Given this list of marker genes CASP8AP2, CD8B, KLHL11, INSM1, TRIM21, ANKRD40, JAKMIP2, TNFSF13, PDLIM2, CNR1, ESPL1, ZCCHC24, SNN, DHX58 (NCBI Gene Id 79132), TTLL4, ZSCAN12, LMNB1, MRGBP, CA12, ASF1B, DDX60, IGHV3-7, BAIAP2, ZNF135, EHMT2, PALMD (NCBI Gene Id 93975), TCL6, TMEM131L, MRPL28, POLD1 (NCBI Gene Id 5424), FBN2, here is a description of the gene set: Human Gene Set: FLOTHO_PEDIATRIC_ALL_THERAPY_RESPONSE_DN Down-regulated genes significantly associated with positive minimal residual disease (MRD) on day 46 after chemotherapy treatment of children with acute lymphoblastic leukemia (ALL). species: Homo sapiens In childhood acute lymphoblastic leukemia (ALL), early response to treatment is a powerful prognostic indicator. To identify genes associated with this response, we analyzed gene expression of diagnostic lymphoblasts from 189 children with ALL and compared the findings with minimal residual disease (MRD) levels on days 19 and 46 of remission induction treatment. After excluding genes associated with genetic subgroups, we identified genes that were significantly associated with MRD. The caspase 8-associated protein 2 (CASP8AP2) gene was studied further because of its reported role in apoptosis and glucocorticoid signaling. In a separate cohort of 99 patients not included in the comparison of gene expression profiles and MRD, low levels of CASP8AP2 expression predicted a lower event-free survival (P =.02) and a higher rate of leukemia relapse (P =.01) and were an independent predictor of outcome. High levels of CASP8AP2 expression were associated with a greater propensity of leukemic lymphoblasts to undergo apoptosis. We conclude that measurement of CASP8AP2 expression at diagnosis offers a means to identify patients whose leukemic cells are highly susceptible to chemotherapy. Therefore, this gene is a strong candidate for inclusion in gene expression arrays specifically designed for leukemia diagnosis. from publication Flotho C, Coustan-Smith E, Pei D, Iwamoto S, Song G, Cheng C, Pui CH, Downing JR, Campana D (PMID 16627760)